Given this list of marker genes ZNHIT3 (NCBI Gene Id 9326), TPR, PDCD10, AGPAT1, SRRT, KLHDC10, ERCC2, PIGF, MRPL28, OSR1, NMT1, UFD1, CDK8, BECN1, GSK3B, GGPS1, TTF2, CDK13, NFATC2IP, KDM3B, ATG9A, MR1, GFUS, DNAJC13, MPST, PRKAG1, TAF9, CSNK1G2, RALB, MEA1, PCGF1, ZNF592, CETN3, CNOT2, RAF1, ROCK1, TOR1AIP1, HUWE1, CHD3, SS18, EML3, NFRKB, TMEM94, OARD1, ENTREP3, MIA2, CSTF3, PPP1R3D, SLC25A11, DDB1, UBE2A, BTD, PCGF2, FAF2, SMAD2 (SMAD family member 2), PIK3R2, PRPF4, SEC23IP, ZNHIT1, RABAC1, NSL1, MRE11, NUBP1, CLPX, TUBGCP2, SNX4, PDXDC1, RABGGTA, HTATSF1, CDYL, TFAP4, WWOX, PWP1, RPRD2, STK38, TMEM11, ILF2, NFYB, OTUB1, XPO6, MFN2, PSMB6, NUP88, JRK, MTX1, FANCG, RING1, CUL4B, CHD8, IRF2, GPATCH8, METAP1, SFSWAP, EXTL3, IGBP1, XPC, SH2B1, FRYL, REV3L, ATRX, PPP2R5E, CSNK1D, DHRS1, TAF2, NELFB, STXBP3, BRD3, TTLL5, KDM5C, TTI1, NCOA6, NKRF (NCBI Gene Id 55922), MYCBP, KIAA0586, FANCI, SDR39U1 (short chain dehydrogenase/reductase family 39U member 1), DDX11, DIMT1, PLIN3, ZFTRAF1, ZBTB22, PPP1R11, DENND4A, PHB1, TERF2IP, INPP5E, BAHD1, FDXR, SULT1A1, SSR1, BAG1, SEC31A, PARN, ILVBL, BPHL, DRAP1, FOXK2, IK, NUP62, B4GALT3, RAB1A, TBPL1, TBCE, RAB11A, PRKCSH, CPSF4, KPNA6, here is a description of the gene set: Human Gene Set: MORF_TPR species: Homo sapiens Neighborhood of TPR translocated promoter region (to activated MET oncogene) in the MORF expression compendium Neighborhood of TPR